The following is a description of a gene set: Any process that results in a change in state or activity of a cell or an organism (in terms of movement, secretion, enzyme production, gene expression, etc.) as a result of a cAMP (cyclic AMP, adenosine 3',5'-cyclophosphate) stimulus. Human Gene Set: GOBP_RESPONSE_TO_CAMP studied in species Homo sapiens, and this is the list of marker genes: CRHBP (corticotropin releasing hormone binding protein), HCN1, REN, SLC5A5, HCN3, CRTC2, HMGCS2, HCN2, KCNQ1, PENK, SLC6A3, AQP1, CNGA3, PIK3CG, KCNE1, PDE4D, CPS1 (carbamoyl-phosphate synthase 1), RAPGEF3, VGF, CFTR, ZFP36L1, AKAP9, EZR, ASS1, DUOX1, PNPT1, RAP1B, AQP9, INHBB, SREBF1, FBP1, RAP1BL, WNT10B, SLC26A3, GUCD1, RAPGEF2, CDO1, NDUFS4, DMTN, AHR, AKAP7, DGKQ, EEF2K, AQP8 (aquaporin 8), ITPR2, WT1, CITED1, DUOX2, FDX1, RELA, CRTC3, INPP5K, KDM1A, OXT, PDE2A, SLC8A3, FOS, ALAS1, RAPGEF1, STAT1, COL1A1, TYR, BIRC2, GPD1, AANAT, THBD, TOP1, ATP5PO, MMP19 (matrix metallopeptidase 19), AKAP6, CARM1, DUSP1, AREG (amphiregulin), HCN4, GATA1, PKLR, CRTC1, TIFAB, PKD2, SLC26A6, PER1, SCX, ADIPOQ, BSG, RAP1A, STC1, APP, FOSB, SRD5A1, IGFBP5